Given this list of marker genes Plxna3, Plxna1, Pitx2, Sema3a, Nrp2, Foxb1, Ndnf, Nrp1, Sema3e, here is a description of the gene set: Mouse Gene Set: GOBP_HYPOTHALAMUS_CELL_MIGRATION species: Mus musculus The directed movement of a cell into the hypothalamus region of the forebrain.